The following is a description of a gene set: species: Mus musculus from publication Sartipy P, Loskutoff DJ (PMID 14530283) Mouse Gene Set: SARTIPY_NORMAL_AT_INSULIN_RESISTANCE_UP Genes up-regulated in 3T3-L1 cells (adipocyte) by insulin which continued to respond normally to insulin in the insulin resistant cells. We have employed microarray technology using RNA from normal 3T3-L1 adipocytes and from 3T3-L1 adipocytes made insulin-resistant by treatment with tumor necrosis factor-alpha to identify a new class of insulin-responsive genes. These genes continued to respond normally to insulin even though the adipocytes themselves were metabolically insulin-resistant, i.e. they displayed a significantly decreased rate of insulin-stimulated glucose uptake. Approximately genes/expressed sequence tags (ESTs) were screened. Of these, genes/ESTs were identified that became insulin-resistant as expected (e.g. Socs-3, junB, and matrix metalloproteinase-11). However, genes/ESTs continued to respond normally to insulin. Although some of these genes were previously shown to be regulated by insulin (e.g. Glut-1 and beta3-adrenergic receptor), other novel insulin-sensitive genes were also identified (e.g. Egr-1, epiregulin, Fra-1, and ABCA1). Real-time reverse transcription-PCR analysis confirmed the expression patterns of several of the differentially expressed genes. One gene that remained insulin-sensitive in the insulin-resistant adipocytes is the transcription factor Egr-1. Using an antisense strategy, we show that tissue factor and macrophage colony-stimulating factor, two cardiovascular risk factors, are downstream EGR-1 target genes in the adipocyte. Taken together, these data support the hypothesis that some signaling pathways remain insulin-sensitive in metabolically insulin-resistant adipocytes. These pathways may promote abnormal gene expression in hyperinsulinemic states like obesity and type II diabetes and thus may contribute to pathologies associated with these conditions., and this is the list of marker genes: Tubb2a, Dusp6, Fosl1, Ereg, Synj2, Cdr2, Hmgcr, Spred2 (sprouty-related EVH1 domain containing 2), Ppan, Spsb1, Ptges, Ifi202b, Noct, Bysl, Ccl2, Phlda1, Nopchap1, Nop58, Mak16, Srxn1, Slc2a1, Bhlhe40, B3gnt2, Slc25a28, Ccl7, Srr, Ier2, Nop56, Hmox1, Tubb6, Ak4